Given this list of marker genes XBP1, GTDC1, ELAVL4, BCL11A, ALDH6A1, APOOL, LIN54, KIF18A, USP3 (ubiquitin specific peptidase 3), CWC27, NHLH2, NHLH1, EWSR1, SLC17A4, NPAS4, MMD, TGFBR1 (NCBI Gene Id 7046), ERICH5, GLS, BAZ2B, MSI2, UQCRB, SLC7A11, ARMC8, NLRP5, DDX17, TGM2, CMTM6, PWP2, FAM13B, EMB, TAF15, PPT1, ARK2N, ADAM7, SYT1, GULP1, COMMD3-BMI1 (NCBI Gene Id 100532731), here is a description of the gene set: Human Gene Set: MIR4999_3P species: Homo sapiens Genes predicted to be targets of miRBase v22 microRNA hsa-miR-4999-3p in miRDB v6.0 with MirTarget v4 prediction scores > 80 (high confidence targets). from publication Chen Y, Wang X (PMID 31504780)